Given this list of marker genes Spg11, Casq1, Homer3, Stim1, Stc2, Gramd2a, Spink1, Nfatc3 (nuclear factor of activated T cells, cytoplasmic, calcineurin dependent 3), Selenok, Homer2, Slc8b1, Orai1, Cracr2a, Orai3 (ORAI calcium release-activated calcium modulator 3), Trpc4, Cracr2b, Homer1, Ms4a1, Cd84, Jph4, Efhb, Stim2, Srl, Orai2, Stimate, Tspan18, Saraf, here is a description of the gene set: studied in species Mus musculus Mouse Gene Set: GOBP_STORE_OPERATED_CALCIUM_ENTRY A calcium ion entry mechanism in the plasma membrane activated by the depletion of calcium ion from the internal calcium ion store in the endoplasmic reticulum.